Given this list of marker genes Map1b, Actn4, Npc1, Mdm2, Vapa, St6gal1, Ssr2, 4930412C18Rik, Nsd3, Gm20655, Ubqln1, Ubxn8, Cgref1, Clca3b, Mrpl3, 9530068E07Rik, Asb15, E030042O20Rik (NCBI Gene Id 320474), Cxcl10, Dnaja1, Cenpo, Tcta, Ube2k, Atg13, Ndel1, Maml3, Cimap2, Strbp, Fxr2, Gm15419, Bend6, Rabl2, Gm23212, Cdt1, Ptrh2, Zfp365, Tomm20, Nacc2, Zc3h3, Ubxn7, Txlnb (NCBI Gene Id 378431), Gm15916, Atp5f1d, Gsta1, Psmb3, D630024D03Rik, Psma7, Msh3, Etfdh, P2rx6, Ufc1, Oxsm, Ankrd48, Sh3tc1, Sos2, Nufip2, Fbxl19, Psmc1, Rraga, Shroom2, Zbtb37, Hspd1, Zfand2a (zinc finger, AN1-type domain 2A), Csf1, Eif4g2, Adrm1, Ctsd, Slc25a24, Snap47, Zer1, Dnai1, Ccdc90b, Eif4g1, Septin9, Als2, Rwdd1, Paics, Rock2, Gm15541, Mocos, Tceanc, Hmbox1, Gm10419, Oser1, Ssc5d, Csnk1g3, Gm22423, Ppp1r12b, Wapl, Cinp, Eif3d, Tafazzin, Ank2, Zfyve19, Gm16023, Smarcad1, Kmt2d, Mgst2, Qsox1, Zfp708, Coasy, Xpc (xeroderma pigmentosum, complementation group C), Gm8321, Lrrc74b, Gm5113, Kcnab1, Fam162a, Sfi1, Gm11550, Fetub, Septin7, 4732419C18Rik, Mir21c, Gm26535, Rbmxl1, Fiz1, Mtx1, Echdc3, Gm23598, 1700086O06Rik, Ythdf2, 4930583K01Rik, Creg1, Guk1, Gm11936, Bptf, Mical1, Fads2, Atp5pd, Mast2, Mcts1, Med24, Aldoa, 4933435F18Rik, Trex1, Mettl21a, Dap, Zfp330, Sptbn1, Psmd1, Col5a1, Usp19, Tenm4, Ints9, Mir344, Rps6, 4930579G24Rik, Psmd14, Tor1aip1, Ptma, Panx2, Alkbh3os1, Cspp1 (NCBI Gene Id 72327), Faf1, Mxd3, Zfp568, Cbr3, Hyal3 (NCBI Gene Id 235600), Chordc1, Scml4, Zfp335os, Psmb5, Map4, 4933440N22Rik, Fgd3, Pdia3, Ap5b1, Ifrd1, Rusc1, Zwint, Ttbk2, Herpud2, Brd2, Zfp786, Rbks, Hsp90b1, Ap1g1, Ruvbl1, Peak1, Gm29642, Tmc6, Zfp1, Pds5a (PDS5 cohesin associated factor A), Pmp22, Map2k7 (NCBI Gene Id 26400), Sec16a, Gcnt2, Tmie, Htr1b, 1700052H01Rik, Mir7214, Dph5, Ptchd4, Snhg17, Plscr3, Gm32585, Dnase1l1, Gm31728, Commd9, Il15ra, Gm9831, Diablo, Trim16, Lgr6, Huwe1, Smg5, Uchl1os, Nxpe3, Epo, Efemp2 (NCBI Gene Id 74808), Trim6, Rnpc3, Efcab2, Ing4, Ahsa1, Akt1s1, Ss18l1, Ndc80, Eloc, 4930592C13Rik, Gosr1, Psen2, Tsen34 (tRNA splicing endonuclease subunit 34), Tmbim6, Dst, Mad1l1, Rps25, Mboat7, Bola1 (NCBI Gene Id 69168), Rad23b, Kctd15, Mir344b, Hars2, Cntd1, Dpysl2, Psmd13, Gm12274, Smc3, Ranbp2, Cnih4, Tuba4a, Wipf2, Supt3, Bicdl1, Fto, Stk40, Gm12976, Slc10a7, Clca4b (NCBI Gene Id 99709), Mcl1, Ak1, Rmc1 (regulator of MON1-CCZ1), Cadm4, Tmem183a (transmembrane protein 183A), Zfp407, Srxn1, Nmt1, Serpinb9, Smad3, Lpin3, Lrrc49, Psmb2, Srd5a3, Phgdh, Atf6b, Cd1d1, Gtf2a1, Sdc4, Tmem167, Tfpi, Crat, G3bp1, Prune1, Il7, Egln2, Rps6ka2, Dpm3, Rai14, Slc11a1, Zwilch, Hsp90aa1, Rcn3, Xpot, Ddx42, Ppcdc, Cpsf1, Fam107b, Babam2, Loxl1, Psmc4, Rabgef1, Krt80, H3c6, Hspe1, Vmp1, A530013C23Rik, Edf1, Ftsj3, Tcea1, Eps8, Bcap29, Zfp60, Gm19391, Mbd1, Ndufa5, Mapk8ip3, Lsm3, Zcwpw1, Trim12c, Ttc28 (NCBI Gene Id 79562), Gm12245, Ube2v1, Cdca2, Il2rb (NCBI Gene Id 16185), Nsmce4a, Atp8b2, Gnb2, Nes, Snrnp70, Zfp516, Gm16184 (NCBI Gene Id 100416336), Gm22489, Zfp566, Atosa, Atp13a4, Pafah1b1, Norad, Sfxn5, Slc25a38 (NCBI Gene Id 208638), Fam180a, Mars1, Txnrd1, Ece2, Gm12542, Numbl, Dynll2 (dynein light chain LC8-type 2), Rffl, 2310022A10Rik, Ptpa, E130317F20Rik, Mir7671, Zfp638, A230001M10Rik, Dph3, Cops2, Pgs1, Cdan1, Nuggc, Cfap410, Frmd8os, Dph7, Cox20, Smim7 (NCBI Gene Id 66818), Snord78, Nav3, Fbxo47, Rpl22, Impact, Prpf4, Mgat2, Dele1, Mrpl32, Nub1, Nme1, Rtca, Rusc2, Syvn1, Tpp2, Tgm2, Bak1, Dpp8, Snord45c, Tef, Cep120 (NCBI Gene Id 225523), Psmb1 (proteasome (prosome, macropain) subunit, beta type 1), Rtl8b, Jak2, Psmd11, Mapk6, Arl16, Xpa, Cdc34, 3110040N11Rik, Kcnq1ot1, Naa12, Cdc25a, Catsper2, Pisd, Slpi, Srrm2, Lmod1 (leiomodin 1 (smooth muscle)), Rhbdd3 (NCBI Gene Id 279766), Zfp287, Acad12, Procr (NCBI Gene Id 98921), Rhog, Camk2b, Hnrnpa1l2-ps, Cox8a, Usp48, Rpgrip1l, Adck1, Canx, Zscan12, Ptges3, Agrp, BC005537, Gm12762, Ccdc47, Tecpr2, Rps15a-ps2, Sec14l1, Vezt, Smim3, Dpf2, Hadh, Acbd5, Galk2, Irgm1, Bcl2l13, Srpk2, Rnmt, Eif3b, Cox14, Gm23143, Pitpnm3, Peds1, Inpp5e, Mir22hg, Mir210, A730081D07Rik, Cdk11b, D030047H15Rik, Ufl1, Trim11, Gm12925, Unkl, 1600020E01Rik, Bdkrb1, Gm12758, Gm40117, Gadd45g, Crem, 4930477O15Rik, Ubfd1, Ncoa7, 4930429F24Rik, Nek1, Gm26224, Atp5po, Cdc26, Mlkl, Vipas39, Cwf19l2, Hdac7 (NCBI Gene Id 56233), Entpd5, Slc25a45, Cnot7, Ppp3r1, Rbbp7, Dynlt1b, Gnat2, Zswim8, Zc2hc1c, B230219D22Rik, Rnft1, Aldh16a1, Dock9, Pakap, Gm13778, Dclk1, Mrps28, Rpl14, Stam, Psmc3, Abhd12, Kank1, Tmcc1, Rhoa, Rps19, Ttc19, Klc1, St7, Arl8a, Keap1, Ppp1r18 (protein phosphatase 1, regulatory subunit 18), Cep164, Tedc2, Gm8098, Tbc1d17, Sccpdh, Ggnbp1, Capn10 (calpain 10), Marcksl1, Gm14002, Rps11 (NCBI Gene Id 27207), Tmsb4x, Mthfd2l, Ppp1r10, Tomm40l, Npcd, Plaa, Oaf, H1f8, Btn2a2, Tbc1d22a (TBC1 domain family, member 22a), Naa25, Slc25a39, Synj2, Trib1 (tribbles pseudokinase 1), Capn2, Mknk2, Fam32a, Fgd6, Pih1d1, Tpm3, Tprn (taperin), Rab9, Mfsd11, Prdx1, Tmc8, Rhbdf2, Gprc5a, Rpl11 (ribosomal protein L11), Shc1, Rheb, Gm22357, Chst15, Ap2b1, Mir707 (microRNA 707), Ly96, Mdc1, Gm13293, Nt5dc1, Poc5, B3gat3, Fbxo34, Nol3, Adnp2, Hspa4, 1700013A02Rik, Shcbp1l, Gm26080, Cltc, Creld1, Gm10516, Ptpra, Zfp771, Zfp524, Calr3, Tnpo1, Ncapd2, Mrps18b, Dzip1l, Pir, Mocs1, Cyb5r3, Stx18, Anp32e, Mir207, Ptpmt1, Tmem41b, Zzef1, AV039307, Atp2b4, Tcea2, Gm20658, Cops5, Flot1, Tsc22d1, Birc6, 0610009E02Rik, Nvl, Luc7l, Leng8, Srsf2, Osgin1, Ubc (ubiquitin C), Cxcl5, Gm7299, Trim2, Gm12056, Dnpep, Mafg, Commd1, Ptpn23 (NCBI Gene Id 104831), Dstn, Mtln, Zfp598, Mrpl14, Il36g, Rcc1l, Hsp90ab1 (NCBI Gene Id 98078), Gm5682, Znrf1, Gstm1, Ogt (NCBI Gene Id 77137), Emilin1, Cct3, Atp6v0a1, Ice2, A830052D11Rik, Mindy1, Cbx6, Gclm, Snx10 (sorting nexin 10), Mt2, Rex1bd, Surf6, Dhx38, Map3k4, Glrx, Slc9a8, Stam2, Gm13470, Tmem39a, Nupr1, Dok7, Rhobtb1, Ago3, Slc17a8, Prcc, Lrrfip2, Fmn1, Usp27x, Eeig1, Prl6a1, Dnmt3l, Nars1, Fbxo44, Ncoa3, Mir22 (microRNA 22), Fam168a, Psmb9, Kbtbd7, Abcb6, Ubqln2, Pcnx4, Srp19, Slc7a2, Phf10, Dnajc17, Gm23100, Layn, Gm16537 (predicted gene 16537), Col7a1 (collagen, type VII, alpha 1), Zfp146, Hapstr1, 4930580E04Rik, Tnrc6b, Cd300lb, Ptk2, Slc22a4, Spata45, Zfp790, Cenpu, Fscn1, Akr1b10, Il6, Dcaf10, Tsacc, Rab39b, Iftap, Gm28857, Uchl1, Rpl4, Smurf1, Rnf4, Chchd5, Brap, Med16, Gsta4, Gm2447, Gsk3b, Ttf1, Ap4e1, C030010L15Rik, Ndufaf4, Msantd5l, Serpinb9b, Sco1, Ubr2, Wasl, Dnajb1, Cuedc1, Dynlt4, Alg8, Rtkn, Atxn7l3, Gm23323, Ttc41, Psmd12, Preb, Gm28809, Ddhd1, Trappc4, 1700010K24Rik, Pura, Midn, Atosb, Zbtb20, Psmb6, Tardbp, Ehd1, Cpeb2, AY074887, Ifi204, Vdac3, Atf7ip, Cyp7b1, Ddx31, Cdc20 (cell division cycle 20), Mmadhc, Maco1, Washc2, Sgms1, Mir3097, Cdc42bpa, Nap1l1, Dennd2d, Ice1, Wipi2, Kdm3a, Ppih, Gm6712, Ibtk, Zranb2, Ppm1f, Mrpl12, Pdzd9, Gm13073, Gapdh, Lix1l, Eif1ax, Arhgap32, Uspl1, Surf1 (surfeit gene 1), Mir34c, Dcakd, Gas5, Ctdp1, Ric8b, Gm11592, Nfe2l1, Ghitm, 4930467K11Rik, Gm14221, Slc7a11, Ndufa10, Ewsr1, Stx6, Pbx4, Nrdc, Dynlt1c, Gins1, Mdn1, 1700101I11Rik, Mtg1 (mitochondrial ribosome-associated GTPase 1), Mindy2, Zswim4, Pou6f1 (NCBI Gene Id 97968), Dhx29, Clk4, Zfpm1, Shbg, Atg5, Gm24494, Mgst1, Atox1, Fbxo7, Gskip, Fam210a, Psap (NCBI Gene Id 19156), Gm12092, Fam219a, Pafah2, Ttc21b, Abcf3, Tex14, Clpp, Map2k4, Csgalnact2, Zfp426, Baz1b, Pold2, Gm15567, Hic1, Cbx5, Gm25408, Sugp2, Rplp2, Txnl4a, Rbm5, Clcf1, Timm13, Pex12, Stx4a, Pdxk-ps, Ears2, Ankle1, Ywhag, Scmh1, Herc2, Mettl27, Akr1b1, Slc43a2 (solute carrier family 43, member 2), Kdm2a, Atf1, Clip1, Gck, Nprl3 (nitrogen permease regulator-like 3), Gm12153, Chtop, Rabggtb, Abcb7, 5730480H06Rik, 2210408F21Rik, Neo1, Me1, Nqo1, Ccdc17, Suv39h1, Pvr, Aebp2, Smg1, AI480526 (NCBI Gene Id 100675), Rpl27, Tbc1d2b, Mir5627 (microRNA 5627), Trdd2, Zfand5, Nsun3, Nav2, Lztfl1, Taf5, Gm13483, Lars2, Psmb4, Arhgap23, Gbe1, Rtl8a, Btbd19, Rap2a, Spsb1, D030040B21Rik, Gm12218, Rptor, Rad51c, Hephl1, Lsp1, Slc20a1, Gm26744, Dnajb2, Ubr3, Rbm27, Sqstm1, Snu13, 9430037G07Rik, Nmrk2, Tmem214, Mir3075, Lin9, Mpzl1, Dysf, Fryl, Txn1, Kctd2, Faf2, Myl6b, Vdac1, Lrrc32, Mocs2, C1galt1c1, Bmpr2, Oxnad1, 2900093K20Rik, Tcf4, Taf7, Tlcd2, Snapin, Psma4, Sqor, Txnl4b, 9330159M07Rik, Psme4, Nrip1, Rnd2, Spata13, Mtmr4, Rpl24, Rtp4, Fancc, Mbnl2, Bcat1, 4933407K13Rik, Ino80, Slc25a3, Csnk2a1, Anapc1, Tbcel, Trdj1, Atxn7l2, Rpl5, Agrn, Aldh18a1, Sirt3, Gm26611, Brk1, Chd1, Arhgap21, Ankk1, Trim30a, Pfn2, Emc7, Rbm26, Tmt1a, 4933433G15Rik, Plec, Txnl1, Surf2, Srpx2, Anks3, Bbs5 (Bardet-Biedl syndrome 5), Mir5131, Xrcc4, Rps9, Slc1a2, Coq8b, Gm22880, Ier3, Smarca2, Cog5, Cdc42se1, Zmynd8, Srpk1, Tns1, Gm20619, Zscan21, Psmd3, Obi1, Fh1, Aox1, Gm5475, Tmem209, Trmt1, Gm12983, Dnajb9, Adamts12, Mtrex, Smyd4, Ap1m1, Megf8, S100a6, Aak1, Gm12513, Pla2g6, Mepce, Mtg2, Ikbkg, here is a description of the gene set: Genes containing one or more binding sites for (Nfe2l1) in their promoter regions (TSS -1000,+100 bp) as identified by GTRD version 20.06 ChIP-seq harmonization. from publication Yevshin I, Sharipov R, Kolmykov S, Kondrakhin Y, Kolpakov F (PMID 30445619) Mouse Gene Set: NFE2L1_TARGET_GENES studied in species Mus musculus